Given this list of marker genes VAV2, RTN4RL1, ZDHHC8, SP1, POLR3H, NRXN1, SYN2, PANK2, TFDP2, NPAS4, WWP1, GALT, TPST1, CD79B, SNIP1, FMR1, EIF4A2, CEP350, RETREG3, AP3S1, RPRM, ATP1B1, ARPC5L, KMT5A, CALU, ZMPSTE24, CRKL, SLC9A1, PCDH9, DYNLT5, SREK1IP1, KLHL28, ARHGAP12, ETF1, CERS5, NAA25, WAPL, F13A1, GLYR1, SRPRA, MAP2, MAX, KDM4C, POU6F1, SECISBP2L, ELFN2, SLC45A3, PSD3, CNN1, ZHX1, RASA1, OLIG3, KAT7 (NCBI Gene Id 63437), CRIM1, HOXD8, SGCD, NAA50, ADGRL2, FAM107B, FAM131B, PPP6C, HAND1, ZSWIM8, SORCS1, IGF2BP2, GLIPR2 (GLI pathogenesis related 2), NR4A3, UBE2H, BSDC1, PHF20L1, LONRF1, MLX, EPB41L4B, CHFR, STARD7, UBE2G1, ISL1, KDM2B, ADCY3, PRPF38B, TRIM13, SH3BP5, ABCC5, STIM2, DCUN1D3, RSBN1, PLOD1, here is a description of the gene set: Human Gene Set: GCTCTTG_MIR335 Genes having at least one occurence of the motif GCTCTTG in their 3' untranslated region. The motif represents putative target (that is, seed match) of human mature miRNA hsa-miR-335 (v7.1 miRBase). studied in species Homo sapiens